The following is a description of a gene set: species: Homo sapiens Human Gene Set: KEGG_MEDICUS_REFERENCE_C9ORF72_MEDIATED_AUTOPHAGY_INITIATION C9orf72-mediated autophagy initiation. Pathway ID: N01142. Pathway type: Reference. Pathway class: nt06532 Autophagy. Pathway Definition from KEGG: RAB1A -> (C9orf72+WDR41+SMCR8) -> ULK1_complex, and this is the list of marker genes: RAB1A, C9orf72, ULK1, ATG13, WDR41, RB1CC1, ATG101, SMCR8